Given this list of marker genes ATP4A, CCKBR, CHRM1, HRH2, GAST, here is a description of the gene set: Human Gene Set: WP_SECRETION_OF_HYDROCHLORIC_ACID_IN_PARIETAL_CELLS species: Homo sapiens Secretion of hydrochloric acid in parietal cells